Given this list of marker genes DHODH, GDF11 (growth differentiation factor 11), PAX3, GPC4, GPC3 (NCBI Gene Id 6394), here is a description of the gene set: Human Gene Set: HP_SUPERNUMERARY_VERTEBRAE Supernumerary vertebrae studied in species Homo sapiens